The following is a description of a gene set: species: Homo sapiens Any process that modulates the frequency, rate or extent of cytoplasmic translation. Human Gene Set: GOBP_REGULATION_OF_CYTOPLASMIC_TRANSLATION, and this is the list of marker genes: HNRNPU, DHX36, DHX9, PABPC1, LIN28A, PAIP1, ZCCHC13, SYNCRIP, UNK, CNBP, CSDE1, FMR1, METTL3, CPEB1, YTHDF2, PKP1, PARP16, MTOR, HNRNPD (heterogeneous nuclear ribonucleoprotein D), PIWIL2, HHEX, IMPACT, CPEB4, YBX3 (Y-box binding protein 3), ZNF385A, NMNAT2, YBX1, RPL13A (ribosomal protein L13a), PKM, CPEB3, CPEB2, IGF2BP1, RBM24, EEF2, ALKBH3, NCK1, AKT2, SH3BGRL